The following is a description of a gene set: Human Gene Set: GOBP_AMIDE_CATABOLIC_PROCESS The chemical reactions and pathways resulting in the breakdown of an amide, any derivative of an oxoacid in which an acidic hydroxy group has been replaced by an amino or substituted amino group. species: Homo sapiens, and this is the list of marker genes: HAL, ALLC, GDA, NT5C, AASS, UROC1, FTCD, NT5C2, NIT1, AMDHD1 (NCBI Gene Id 144193), PM20D1, XDH, TDO2, ADA, DLST, PIPOX, AADAT